Given this list of marker genes NOL9, ZNF490, KLHL9, KCNIP1, CASP10, LIMK2, KCNJ10, TJP3, RBMX, MSN, EIF4EBP2, GNAT1, CYP20A1, IRGQ, DEPDC5, KCNK16, TSPAN18, TMPPE, MEIS3, HACD4, EPB41L1, CYP4V2, PAPOLG, ARGFX, IKZF3, ORAI2, CLCC1, S1PR2, SLC4A8, CDR2L, FAM162B, B9D1, VPS37C, METTL21A, ATF7, MEST, RIMS3, ENTPD1, DISC1, RBMS2, ELK1, VPS26C, ZNF544, ATXN2L, STXBP6, GDI1, PCYT1B, GLS, CEBPZOS, EEF2K, COL11A2, CAPN6, MPIG6B (megakaryocyte and platelet inhibitory receptor G6b), ATCAY, ZNF548, SV2C, RPL15, SPATA19, MEX3A, TSKU (tsukushi, small leucine rich proteoglycan), PPM1F, PITPNM2, PNPO, SLC30A7, NDST1, KCTD10, ZNF626, SCAI, LRPAP1, TEAD3, EYA3, SCN1B, PDE7A, GLG1, CCL16, ATP5MC2, PLCXD1, CYP1A2, SLC25A45, PRKCA, LRRC55, BZW1, PACS1, MYO10, SLC8A1, RAB15, PLAGL2, SENP5, RPH3AL, SYT15, ANKRD13C, NUP43, ZCCHC24, TMEM106A, ABCC1, RALB, AR, APELA, RRP15, FBXL20, MEFV, CIT, LORICRIN, CHRNB4, CBL, NPAS3, SH3BP2, MYORG, CENPO, SHISA7, ZNF391, VPS25, FUS, TMEM63C (transmembrane protein 63C), GNL3L, ADAMTS4, ZNF248, FBXL18, ELOA2, ZNF814, TRAPPC9, FOXK1, FNIP1, SUSD5, PRKCI, PGM2L1, WDR47, DDA1, SLC6A11, NDOR1, PCDHB9, HSPB2, MDM4, FOXP4, CAMSAP1 (calmodulin regulated spectrin associated protein 1), HECTD4, SGMS1, MPP2, CASTOR2, ZNF772, MYO1F, MIP, HTR3D, GFOD2, SYN2, ABHD4, RTKN, MTCL2, SLC35F6, MTFMT, TIAM1-AS1, here is a description of the gene set: Human Gene Set: MIR6799_5P Genes predicted to be targets of miRBase v22 microRNA hsa-miR-6799-5p in miRDB v6.0 with MirTarget v4 prediction scores > 80 (high confidence targets). studied in species Homo sapiens from publication Chen Y, Wang X (PMID 31504780)